The following is a description of a gene set: The activation of muscle-specific gene expression requires the coordinated action of muscle regulatory proteins and chromatin-remodeling enzymes. Microarray analysis performed in the presence or absence of a dominant-negative BRG1 ATPase demonstrated that approximately one-third of MyoD-induced genes were highly dependent on SWI/SNF enzymes. To understand the mechanism of activation, we performed chromatin immunoprecipitations analyzing the myogenin promoter. We found that H4 hyperacetylation preceded Brg1 binding in a MyoD-dependent manner but that MyoD binding occurred subsequent to H4 modification and Brg1 interaction. In the absence of functional SWI/SNF enzymes, muscle regulatory proteins did not bind to the myogenin promoter, thereby providing evidence for SWI/SNF-dependent activator binding. We observed that the homeodomain factor Pbx1, which cooperates with MyoD to stimulate myogenin expression, is constitutively bound to the myogenin promoter in a SWI/SNF-independent manner, suggesting a two-step mechanism in which MyoD initially interacts indirectly with the myogenin promoter and attracts chromatin-remodeling enzymes, which then facilitate direct binding by MyoD and other regulatory proteins. Human Gene Set: DELASERNA_MYOD_TARGETS_DN from publication de la Serna IL, Ohkawa Y, Berkes CA, Bergstrom DA, Dacwag CS, Tapscott SJ, Imbalzano AN (PMID 15870273) Genes down-regulated in NIH 3T3 cells (fibroblasts) 24 h after inducing MyoD differentiation program. species: Mus musculus, and this is the list of marker genes: POSTN, SLC5A3 (solute carrier family 5 member 3), MPP7, FZD1, PDE4B, MGST1, IFITM1, ZNF777, PRDX4, TPR, S1PR3, DDX28, COL11A1, ACTL6B, BAIAP2, FNBP4, TUT4, PLP2, TGFBI, VASN, ATP6V0C, SERPINB9, CCDC24, HMGB3, ITPR2, STARD4, STXBP5, CXCL12, TTYH3, GAPT, CD34, PTEN, THBD (thrombomodulin), SYNPO, ADGRA2, KLF6, GBP2, TCF7L1, DDIT3, ARL14EP, EMILIN2, CYB5A, DPYSL2, MMP2, ZC3H11A, ZMYND8, SDC2, RBPMS, CAPN6 (calpain 6), RAB24, ERBIN, SLIT2, BASP1, CD47, POLE2, CENPM